Given this list of marker genes EYA1, CHN1, SIX5, SALL4, MAFB, SIX1, here is a description of the gene set: Gustatory lacrimation results from an aberrant innervation of fibers from the seventh cranial nerve to the pterygopalatine ganglion which are destined originally for the submandibular ganglion. This aberrant innervation leads to uncontrollable tearing while eating or in anticipation of a meal. studied in species Homo sapiens Human Gene Set: HP_GUSTATORY_LACRIMATION Gustatory lacrimation